The following is a description of a gene set: The component of the presynaptic endocytic zone membrane consisting of gene products and protein complexes that are loosely bound to one of its surfaces, but not integrated into the hydrophobic region. Human Gene Set: GOCC_EXTRINSIC_COMPONENT_OF_PRESYNAPTIC_ENDOCYTIC_ZONE_MEMBRANE studied in species Homo sapiens, and this is the list of marker genes: DNAJC6, AP2B1, AP2M1, PICALM, SNAP91